The following is a description of a gene set: Th1 and Th2 cells arise from a common precursor cell in response to triggering through the TCR and cytokine receptors for IL-12 or IL-4. This leads to activation of complex signaling pathways, which are not known in detail. Disturbances in the balance between type 1 and type 2 responses can lead to certain immune-mediated diseases. Thus, it is important to understand how Th1 and Th2 cells are generated. To clarify the mechanisms as to how IL-12 and IL-4 induce Th1 and Th2 differentiation and how TGF-beta can inhibit this process, we have used oligonucleotide arrays to examine the early polarization of Th1 and Th2 cells in the presence and absence of TGF-beta after 0, 2, 6 and 48 hours of polarization. studied in species Homo sapiens Genes down-regulated in CD4 T cells activated by anti-CD3 and anti-CD28: IL-12 (6h) versus IL4 (6h). Human Gene Set: GSE2770_IL12_VS_IL4_TREATED_ACT_CD4_TCELL_6H_DN from publication Lund R, Aittokallio T, Nevalainen O, Lahesmaa R (PMID 14607935), and this is the list of marker genes: KCMF1, IGFBP7, NDFIP2, VKORC1L1, PHPT1, HNRNPH2, SNX8, HECTD3, P3H3, FBXL12, DNAJC15, GSTK1, ATOSA, PIAS1 (protein inhibitor of activated STAT 1), CKB, IQGAP1, THOC3, THNSL1, CD244, LCLAT1, ST7, NCOR1, DDX28, FERRY3, CFAP68, CLASP1, SPRED2, MYL4, DYRK2 (NCBI Gene Id 8445), COX14, CYP51A1, MRPL23, NRAS, HS1BP3, TSHZ3, AAGAB, GALNT1 (NCBI Gene Id 2589), CDK2 (cyclin dependent kinase 2), GPAA1, TFCP2 (transcription factor CP2), ZNHIT6, AP1S3, PHAX, KYAT3, COA5, BAX, TEX2, ING4, PEDS1, RCOR3, RNF31, SMC4, TUFM, THAP1, KLF7, SEC11A, HSD17B4, POLR2I, PIK3CB, SUCO, AGK, DENND2C, COPZ1, VASP, PPP6C, MYEF2, INPP5F, MCEE, NRBP1, IMMP2L, SPRTN, PPP3CA, BRD3, PRKRA, DSTYK, GZMB, RTN3, GATAD1, RTL8C, RILPL2, PITHD1, SCAMP2, EIF3K, ADGRE5, SLCO3A1, PPHLN1, BCL10, ST8SIA6, ATXN1L, ZNF22, PCBD2, CENPL, NR2C1, MCM9, RAP1GDS1, MRPL32, GTF3C6, CYP11B1, PLK2 (polo like kinase 2), TMEM87A, RNF150, AXL, RANBP10, YPEL3, ATRAID, DNAJC24, EIF4E3, ATF7IP, PECR, BIN3, TMEM176B, TMEM9B, WSB2, SNN, PDE4B, ACTR1A (NCBI Gene Id 10121), TTC28, APOE, ESYT2, SRRM1, RALA, NBEAL2, WDR26, RAP1GAP2, IRF4, HCST, TMEM267, CIRBP, PRICKLE3, BRCA2, TCOF1, CUL1, PDCD1, UBR2, MAPK14, PHF1, CARHSP1, GATM (glycine amidinotransferase), NCKAP1L, ITGB2, CD207, RNF24, TMEM184B, ANKHD1, PRR13, TRIT1, IL4I1, MTPAP, SLF2, ATAT1, E2F5, UQCR11, NDUFA7, FAM162A, MRPL1, DDX19B, IMP3, CLIC4, RNF4, CD69, HLA-DRB1, FAM216A, AKNA, TIMM10, AK2 (NCBI Gene Id 83165), MANBAL, CMC1, KRIT1, ENDOD1, SREBF1, EMP3, CHURC1, STK38, NECAP2, RGMB, CDKN1A, BMPR2, LDLRAD3, TIMM50, MFHAS1, MKRN2, PPIH, ETS1, FUT11, MAPK7, PHKA1, SS18L2, TAF3 (NCBI Gene Id 83860), FSCN1, SIX5, HSBP1, GADD45A, SKAP1, BUD23, IPCEF1, GAS8, MCTS1, ZNF471, KIT, RFESD